Given this list of marker genes Sgo1, Ccnb1, Fzr1, Ppp2r2a, Mis18bp1 (MIS18 binding protein 1), Ppp2r1a, Ppp2r3d, Ppp2cb, Foxm1, Cdk2, Cdc25b, Ppp2r1b, Pkmyt1, Ticrr, Ppp2ca, Wee1, Ccnb2, Ppme1, Mnat1, Hjurp, Ccnh, Ccna1, Plk1, Lcmt1, Obi1, Cdc25a, Cdk7, Bora, Ccna2, Xpo1 (exportin 1), Cdc25c, Cdk1, here is a description of the gene set: Mouse Gene Set: REACTOME_CYCLIN_A_B1_B2_ASSOCIATED_EVENTS_DURING_G2_M_TRANSITION Cyclin A/B1/B2 associated events during G2/M transition species: Mus musculus